The following is a description of a gene set: studied in species Homo sapiens Human Gene Set: GOBP_MACROMOLECULE_DEPALMITOYLATION The removal of palymitoyl groups from a macromolecule., and this is the list of marker genes: ABHD12, LYPLA2, ABHD10, LYPLA1, DESI2, PPT1, ABHD17B, ABHD13, PPT2, ABHD17A, ABHD17C, DESI1, CPT1C, LYPLAL1